Given this list of marker genes GHSR, GHRL, KIT, SPX, NMU, here is a description of the gene set: Human Gene Set: GOBP_POSITIVE_REGULATION_OF_GASTRO_INTESTINAL_SYSTEM_SMOOTH_MUSCLE_CONTRACTION Any process that activates or increases the frequency, rate or extent of gastro-intestinal system smooth muscle contraction. species: Homo sapiens